The following is a description of a gene set: Human Gene Set: BONOME_OVARIAN_CANCER_POOR_SURVIVAL_DN Despite the existence of morphologically indistinguishable disease, patients with advanced ovarian tumors display a broad range of survival end points. We hypothesize that gene expression profiling can identify a prognostic signature accounting for these distinct clinical outcomes. To resolve survival-associated loci, gene expression profiling was completed for an extensive set of 185 (90 optimal/95 suboptimal) primary ovarian tumors using the Affymetrix human U133A microarray. Cox regression analysis identified probe sets associated with survival in optimally and suboptimally debulked tumor sets at a P value of <0.01. Leave-one-out cross-validation was applied to each tumor cohort and confirmed by a permutation test. External validation was conducted by applying the gene signature to a publicly available array database of expression profiles of advanced stage suboptimally debulked tumors. The prognostic signature successfully classified the tumors according to survival for suboptimally (P = 0.0179) but not optimally debulked (P = 0.144) patients. The suboptimal gene signature was validated using the independent set of tumors (odds ratio, 8.75; P = 0.0146). To elucidate signaling events amenable to therapeutic intervention in suboptimally debulked patients, pathway analysis was completed for the top 57 survival-associated probe sets. For suboptimally debulked patients, confirmation of the predictive gene signature supports the existence of a clinically relevant predictor, as well as the possibility of novel therapeutic opportunities. Ultimately, the prognostic classifier defined for suboptimally debulked tumors may aid in the classification and enhancement of patient outcome for this high-risk population. from publication Bonome T, Levine DA, Shih J, Randonovich M, Pise-Masison CA, Bogomolniy F, Ozbun L, Brady J, Barrett JC, Boyd J, Birrer MJ (PMID 18593951) Top highly correlated genes negatively associated with poor survival of patients with suboptimally debulked ovarian tumors. studied in species Homo sapiens, and this is the list of marker genes: HDHD3 (NCBI Gene Id 81932), SRRT, MTAP, TWNK, H2BC3, PPAN, HNRNPU, PAOX (polyamine oxidase), BOP1, ACOT7, KRT8P11, ASPSCR1, COLGALT1, GRK6, PRKD3, FCHO1, IL18BP, SS18, CLN6, EHMT2, LPAR2, DNASE2